The following is a description of a gene set: Our data indicated that activation of the PPARg nuclear receptor induces a retinoid response in human dendritic cells. In order to assess the contribution of retinoid signaling to the PPARg response we decided to use a combination of pharmacological activators and inhibitors of these pathways. Cells were treated with the synthetic PPARg ligand rosiglitazone (RSG), or with RSG along with the RARa antagonist (AGN193109) to block RARa mediated gene expression, or the RARa specific agonists (AM580) alone. This design allows one to determine if retinoid signaling is a downstream event of PPARg activation and what portion of PPARg regulated genes are regulated via induced retinoid signaling. from publication Szatmari I, Pap A, Rühl R, Ma JX, Illarionov PA, Besra GS, Rajnavolgyi E, Dezso B, Nagy L (PMID 16982809) Genes up-regulated in monocyte-derived dendritic cells: rosiglitazone versus AM580. species: Homo sapiens Human Gene Set: GSE5679_PPARG_LIGAND_ROSIGLITAZONE_VS_RARA_AGONIST_AM580_TREATED_DC_UP, and this is the list of marker genes: WDR83OS, UBE2QL1, TMEM237, PDE6D, UQCR10, CD68 (CD68 molecule), SMDT1, UQCC2, CACNA1S (NCBI Gene Id 779), PHLDB1, TBCB, FAM162A, SNF8, ST6GALNAC6, RBM15B, SPATA24, NUP133, ANKRD37, CCHCR1, ZNHIT1, CHCHD10, BRMS1L, MPV17L2, CDC42EP4, C11orf24, PAFAH1B3, LIG1, CTC1, SUPT3H, VAT1L, TPI1, CEBPA, MRPL51, VASH1, DLL3, TBL2, PXMP2, HMGB3, RNF157, SNRNP25, PPP1R11 (NCBI Gene Id 9160), PDE6A, PRKRIP1, CCDC34, DNAJC15, MAPK1 (NCBI Gene Id 5594), COX6B2, NDUFB2, PLPP1, TMEM41B, IMPA2, TMEM147, SLC25A39, LMNB2, PGAM1, C19orf47, CCP110, GALK1, TG, LRBA, NXT1, TMEM256, CMC2, KLF7, NUDT5, ITSN1, CISD1, CHCHD6, SNX3, CYB561, PPFIBP1 (PPFIA binding protein 1), CDR2L, ATL2, TAF11, HK2, NAA38, SLC9A5, ITGB6, NDUFAF7, GMDS, MRPL14, MOGAT2, SEPTIN8, UCK2, NSMCE2, SDR39U1, ALDOC, SUMO3, MAPKAPK2, ABHD14A, CISD3, TFRC, GTF2IRD1, UBXN11, SFMBT1, ARL2, PDXP, IRAK1BP1, PSMA7, EZH2, KRT36, CD248, SRD5A1, BRME1, PDCD1LG2, IMMP2L, MIF4GD, CORO1C, TXN (thioredoxin), TPD52, MARCKSL1, PLA2G4C, PGK1, CDIN1, SCRN3, UGDH, CUEDC2, GINS3, ANXA4, MTHFD2, SAMD14, MRPL54, CNTLN, VWA7, PECR, TSN, COBLL1, RBBP7, SF3B5, MIF, HIVEP3, FOXRED2, DHDDS, FOCAD, PSMG4, ALAD (NCBI Gene Id 210), BHLHE40, POLDIP2, EEPD1, CAMK2N2, SENP1, MAGED1, RBMX, SEMA4C, THAP7, HSPB6, SPEF1, ROCK2, ATP5MF, AK7, TRAPPC2B, INSIG1, COA3, NUCB2, ENDOD1, SPTSSA, TUBE1, VAMP5, PELP1, MYBL1, PTGIR, ERI2, ARFGEF3, HNRNPA3, LRRC75A (NCBI Gene Id 388341, leucine rich repeat containing 75A), CENPN, CHML, PHB1, FZD4, CA11, STARD3NL, ATP5MC3, CENPB, COX7A2, ETHE1, GTF2H5, MZT2B, JPT1, CLTB, ZNF414, HDHD3, COQ3, TUBA8, ADTRP, TMEM107, MYO1B (NCBI Gene Id 92451), UQCRQ, GALR2, P2RY1, ACYP2, MED9, YES1, PKM, FOXK2, LURAP1, ITGB1 (integrin subunit beta 1), FAF1, NRGN (NCBI Gene Id 4900), TRAK1, HMGN3